The following is a description of a gene set: studied in species Homo sapiens Human Gene Set: chr14q24, and this is the list of marker genes: PNMA1, RDH12, GALNT16-AS1, ZDHHC22, FLVCR2-AS1 (NCBI Gene Id 102724153), SIPA1L1, RNU6-419P, MIDEAS-AS1, PROX2, TMEM229B, COQ6, RBM25-AS1, C14orf178, ENSG00000303418, RPL7AP5, RDH11, YLPM1, ERH (NCBI Gene Id 95660), ALDH6A1, RNA5SP388, ZC2HC1C, IRF2BPL, LIN52, ISM2, LINC02274, CCDC177 (coiled-coil domain containing 177), ENSG00000258422, SMOC1, AHSA1, PSEN1 (NCBI Gene Id 5663), ABCD4, VRTN, ZNF410, ANGEL1, JDP2-AS1 (NCBI Gene Id 101928377), ZFYVE26, HMGN1P3, ALKBH1, BATF, RIOX1, ADCK1, NGB (NCBI Gene Id 731373), COX7A2P1, RNU2-51P, TGFB3-AS1, NRXN3, ESRRB, RN7SL369P, MIR7843, COX16, SUB1P2, PTTG1P1, MIR1260A, ENSG00000258623, DCAF5, LINC01629, PGF, ENSG00000308756, TTC9, LINC02289, NT5CP2, MIDEAS, LINC02288, EXD2, ACOT6, MIR4709, AREL1, PLEKHH1, SYNJ2BP, RPS26P48, PLEK2, RBM25, RN7SL706P, RNU6-689P, RAD51B, RPS6KL1, SLC10A1, DLST, ZFYVE1, TGFB3 (transforming growth factor beta 3), DCAF4, RN7SL356P, KRT18P7, VIPAS39, BANF1P1, FOS, SRSF5, PLEKHD1, RN7SL587P, SUSD6, MIR5694, PAPLN, ZMYND19P1, ACYP1, RN7SL683P, MED6, NPC2, PIGH, VASH1, ACOT4, METTL5P1, GALNT16, RNU6-240P, NUMB, NOXRED1, NEK9, FAM161B, TMEM183AP4, RNA5SP386, RPL7AP6, RNU6-921P, RN7SL77P, LTBP2, RPSAP3, COX6CP11, ACTN1, RNU6-659P (NCBI Gene Id 106481390), MAP3K9-DT, LRRC74A, DPPA5P4, RNU4ATAC14P, NDUFB8P1, ACOT2, MAP3K9, LINC01220, ADAM21, ADAM21P1, GPATCH2L (G-patch domain containing 2 like), HIF1AP1, SNW1, MIR4505, H1-8P2, NT5CP1, RN7SL108P, SLIRP, BLZF2P, ADAM20P1, RNA5SP387, RPS2P2, VSX2, ENSG00000307986, ZFP36L1, RPL21P10, DPF3, HEATR4, VTI1B, ACTN1-DT, TMED8, POMT2, ISCA2, ADAM20, ENTPD5, SLC39A9, PCNX1, GSTZ1, RN7SKP17, SYNJ2BP-COX16, RPS29P1, TMEM63C, RAP1AP, LINC01269, ENSG00000285518, IFT43, RPL36P3, ARG2, MLH3, SNORD56B, EIF2B2 (NCBI Gene Id 8892), RPL21P9, TTC9-DT, ENSG00000221060, CYCSP1, DDX18P1, FAM204DP, SAMD15, FLVCR2, RPL22P2, MAGOH3P, FCF1, SIPA1L1-AS1, PAPLN-AS1, ERG28, ENSG00000258874, SPTLC2, RN7SL530P, ACOT1, SYNDIG1L, DNAL1, VASH1-DT (VASH1 divergent transcript), GTF3AP2, RGS6, RN7SL586P, JDP2, TTLL5, SLC8A3, PTGR2 (prostaglandin reductase 2), CIPC, RPL12P7, BBOF1 (basal body orientation factor 1), FXNP1, TMED10, RN7SL213P, PPIAP6